Given this list of marker genes Klf2, Fcer2a, Cxcr4, Uba52, Ccr7, Pax5, Ets1, Stk17b, Spib, here is a description of the gene set: Cytokines mediate cell-cell communication in the immune system and represent important therapeutic targets. A myriad of studies have highlighted their central role in immune function, yet we lack a global view of the cellular responses of each immune cell type to each cytokine. To address this gap, the authors created the Immune Dictionary, a compendium of single-cell transcriptomic profiles of more than 17 immune cell types in response to each of 86 cytokines (>1,400 cytokine-cell type combinations) in mouse lymph nodes in vivo. A cytokine-centric view of the dictionary revealed that most cytokines induce highly cell-type-specific responses. For example, the inflammatory cytokine interleukin-1β induces distinct gene programmes in almost every cell type. A cell-type-centric view of the dictionary identified more than 66 cytokine-driven cellular polarization states across immune cell types, including previously uncharacterized states such as an interleukin-18-induced polyfunctional natural killer cell state. species: Mus musculus Mouse Gene Set: CUI_B_CELL_IL15_RESPONSE_DN from publication Cui A, Huang T, Li S, Ma A, Pérez JL, Sander C, Keskin DB, Wu CJ, Fraenkel E, Hacohen N (PMID 38057668) Genes negatively differentially expressed in cell type: B cell upon treatment with cytokine: IL-15 in mouse lymph nodes in vivo.